Given this list of marker genes ENPP1, TGFB3, TGFB2, CTNNB1, DLG4, COL5A2, USP8, ATRX, GNAS, TERT, TGFBR1, ZNRF3, KDM1A, ABCC6, SMAD2, PDE11A, AIP (aryl hydrocarbon receptor interacting protein), USP48, CUL4B, SPEN, TNXB, COPB1 (COPI coat complex subunit beta 1), FBN1, IPO8, COL1A1, TGFBR2, CHD8, ARMC5, PRKAR1A, BRAF, CDH23, NR3C1, TP53, COL5A1, LOX, CDKN2A, SMAD3, FBXO11 (F-box protein 11), BGN, here is a description of the gene set: species: Homo sapiens Human Gene Set: HP_STRIAE_DISTENSAE Thinned, erythematous, depressed bands of atrophic skin. Initially, striae appear as flattened and thinned, pinkish linear regions of the skin. Striae tend to enlarge in length and become reddish or purplish. Later, striae tend to appear as white, depressed bands that are parallel to the lines of skin tension. Striae distensae occur most often in areas that have been subject to distension such as the lower back, buttocks, thighs, breast, abdomen, and shoulders. Striae distensae